Given this list of marker genes RSRP1, COL5A1, ADAM19, RNF111, MYCBP2, SESN3, TREM1, RAPGEFL1, MED26, TRDN, PPP2R5A, XYLT1, BACH2, FGD4, TNIP1, SLTM, ATXN7, DNMT3A, MEF2C, CCNL1, MAGEB6, BCAT1, TCEAL4, VCPIP1, ABHD14B, SFT2D2, MINAR1, NECAP1, SOX18, TBC1D1, E2F3, MALRD1, ABHD10, OTX2, RNF139, APLP2, GPBP1, CYP19A1, SLF2, CUL3, CREBBP, SSPN, MEF2A, TMEM87A, SBNO1, NEK1, FLNB, TOMM70, DCTN4, PKNOX2, OGT, LILRB4, TM2D2, RIPOR2, PHKA1, AGFG1 (ArfGAP with FG repeats 1), ORC4, RAP2A, PLPPR4, PSMD11, NDFIP1, CENPM, KLF12 (NCBI Gene Id 82238), CREG2, SFRP4, PAX9, CCNK, UBE2E1, IL1R1, GLCE, BRD1, SEMA6D, CAB39L, GAREM2, UBFD1, RPE65, RAB31, PCDH17, COPZ1, DST, TAFA4, MRPL43, PRKAA2, HERC4, ENDOD1, FAM193A, ATXN2, ZFP90, TMEM70, RNF169, PDPK1, ZFAND5, ETV6, COL12A1, CREM, CPEB2, PDZD9 (NCBI Gene Id 255762), COL6A2, CDK13, ARID1A, SIPA1L1, ARHGAP20, TENT5C, USP8, NAT8L, ARSD, PPP2R3A, FAM217B, WDFY3, AHCYL1, AADACL2, HNRNPR, RASSF10, MGST2, ATP6V1A, DDX3X, NEK9, APPBP2, NTM, LSM14A, RBMS3, ANKLE2, INVS, INO80D, here is a description of the gene set: from publication Chen Y, Wang X (PMID 31504780) Human Gene Set: MIR2276_3P Genes predicted to be targets of miRBase v22 microRNA hsa-miR-2276-3p in miRDB v6.0 with MirTarget v4 prediction scores > 80 (high confidence targets). species: Homo sapiens